The following is a description of a gene set: species: Mus musculus Mouse Gene Set: GOBP_HEMATOPOIETIC_OR_LYMPHOID_ORGAN_DEVELOPMENT The process whose specific outcome is the progression of any organ involved in hematopoiesis (also known as hemopoiesis) or lymphoid cell activation over time, from its formation to the mature structure. Such development includes differentiation of resident cell types (stromal cells) and of migratory cell types dependent on the unique microenvironment afforded by the organ for their proper differentiation., and this is the list of marker genes: Aire, Slc46a2, Tnfsf11, Mir188, Fgf3, Nkx2-3, Il7r, Trp53, Hand2, Nkx2-5, Bcl2, Ripk3, Prdx2, Mafb, Apc, Ada, Epb42, Asxl1, Nkx3-2, Carmil2, Tox, Artn, Lmo4, Spns2, Stat5a, Hes1, Kmt2a, Onecut1, Chaserr, Tgfb1, Foxn1, Il15, Flvcr1, Cacnb4, Hoxa3, Map2k2, Tcf21, Adrm1, Mad1l1, Abl1, Flt3, Fgf10, Tnfrsf11a, Six4, Ccr7, Prkdc, Ptprc, Sbds, Rc3h1, Rag1, Cfc1, Rorc (NCBI Gene Id 19885), Raf1, Traf3ip2, Nfkbiz, Gata3, Cd2ap (CD2-associated protein), Jak3, Polb, Tgfbr1, Cdkn2b, Bcl2l11, Bcl3, Ccnb2, Ctnnb1, Nfkb1, Ctc1, Ltb, Pbx1, Cxcl13, Ahr, Tet2, Tlx1, Tcf3, Cxcr5 (NCBI Gene Id 12145), Fas, Ikzf1, Jarid2, Pitx2, Coa5, Adam17, Crkl, Cdh17, Shh, Bcl11b (NCBI Gene Id 78682), Atm, Foxl1, Dicer1, Sco1, Zmpste24, Samd9l (sterile alpha motif domain containing 9-like), Mapk1, Fam210b, Map2k1, Six1, Ret, Pdpn, Ccl21a, Rbm15, Ppp2r3c, Foxi3, Psen1, Lta, Tbx1, Fancb, Rcbtb2, Lrp5, Ephb3, Ltbr (lymphotoxin B receptor), Gba1, Mapk3, Slc40a1, Myb (NCBI Gene Id 97674), Srf, Cd248, Id2, Pax1, Lipa, Fadd, Braf, Pkn1, Stat5b, Cited2, Lrrc17, Tyr (tyrosinase), Bmncr, Nfkb2, Pcid2, Foxe1, Hoxb4, Psen2, Zbtb1, Nfatc3, Barx1, Rc3h2